Given this list of marker genes Gdpd5, Enpp6, Gpcpd1, Gde1, Gdpd2, Gdpd4, here is a description of the gene set: species: Mus musculus Mouse Gene Set: GOMF_GLYCEROPHOSPHODIESTER_PHOSPHODIESTERASE_ACTIVITY Catalysis of the reaction: a glycerophosphodiester + H2O = an alcohol + sn-glycerol 3-phosphate.